Given this list of marker genes GYG1, GYS1, here is a description of the gene set: Glycogen synthase 1 (GYS1 "muscle") is widely expressed in the body. It normally catalyzes the addition of glucose residues to a growing glycogen molecule. In its absence, glycogen synthesis fails. This deficiency is most prominently associated with exercise intolerance and cardiomyopathy. species: Homo sapiens part of: Glycogen storage diseases Reactome Pathway: Glycogen storage disease type 0 (muscle GYS1)